The following is a description of a gene set: studied in species Mus musculus Binding to a DNA polymerase. Mouse Gene Set: GOMF_DNA_POLYMERASE_BINDING, and this is the list of marker genes: Ptges3, Smg6, Hnrnpa2b1, Pcna, Hmgb1, Ncoa2, Hsp90aa1, Polg2, Nat10, Nhej1, Ptges3-ps, Smarca4, Rad51, Hsp90ab1, Cdk2ap1rt, Acd, Lonp1, Fancd2, Paxx, Rtel1, Cdk2ap1, Cdt1, Nabp2 (NCBI Gene Id 69917), Fanci